Given this list of marker genes MAPKAPK2, CREB1, RPS6KA3, RPS6KA1, RPS6KA2, RPS6KA5, ATF1, here is a description of the gene set: Nerve growth factor (NGF) activates multiple signalling pathways that mediate the phosphorylation of CREB at the critical regulatory site, serine 133. CREB phosphorylation at serine 133 is a crucial event in neurotrophin signalling, being mediated by ERK/RSK, ERK/MSK1 and p38/MAPKAPK2 pathways. Several kinases, such as MSK1, RSK1/2/3 (MAPKAPK1A/B/C), and MAPKAPK2, are able to directly phosphorylate CREB at S133. MSK1 is also able to activate ATF (Cyclic-AMP-dependent transcription factor). However, the NGF-induced CREB phosphorylation appears to correlate better with activation of MSK1 rather than RSK1/2/3, or MAPKAPK2. In retrograde signalling, activation of CREB occurs within 20 minutes after neurotrophin stimulation of distal axons. part of: MAPK targets/ Nuclear events mediated by MAP kinases; Nuclear Events (kinase and transcription factor activation) Reactome Pathway: CREB phosphorylation studied in species Homo sapiens